Given this list of marker genes MRPL45, S100A11, KRBA1, PLPP1, PHB1, STMP1, DGKE, KDM2B, NEDD9, CLCF1, CDK1, PIP4K2A, FAM53A, TMEM35A, COPS7A, APOOL, FNBP4, PTPRCAP, NFKBIA, IDH3A, DUSP2 (dual specificity phosphatase 2), C1QBP, GBP6, SUGP1, XIST, NUFIP1, LHPP, ABCA3, ZNF654, PHIP (pleckstrin homology domain interacting protein), TMEM19, PPP4R3B, PTCD2, RPAP3, WDR26, STAT6, NCOA2, KANSL2, TDP2, LSM3, COX17, MRPS14, ETFA, IGSF9, MLLT3, AKR1A1, CELSR1, ERAL1, SLC9A8, GTF2H3, MTHFS, GPHN, TOPBP1 (DNA topoisomerase II binding protein 1), OCIAD1, IFNG, TNFSF8, BAG2, TM2D3, FBXO11, MAPK1, TMEM71, LACTB, POLK, NAA20, PARN, LYSMD2, MGST2, DUT, DNAJC28, TM9SF4, MRPL22, IFT27, STAG2, TUBGCP5, CEBPZOS, SHPRH, BPHL, LYPLAL1, CCDC47, PURG, MINDY3 (NCBI Gene Id 80013), RHOD, PPM1A, ALCAM, MDM2, CASP1, RGS3, NUDCD1, FOXO3, RNF135, FEN1, ARL4A, NFKB2, HERC4, POLR2G, IL2, SEPTIN2, PPCDC, SGMS1, RAMP3, RARG, NTRK3, FBXL20, BCAP29, DMD, GRIA3, DBT, TOP3B, TNFRSF14 (TNF receptor superfamily member 14), SRPK2, NUP85, GNPAT, DFFB, GTF2H1, SLFN13, NOTCH2, TCF7, DDX39B, MCCC1, IGF1R, SYNGR2, IMMT, DCAF12, CCN4, TMC6, CYBA, ILF3, MRPL16, SELENOS, TSTD1, IRAK1, NR3C1, NUP37, TRAF5, M6PR, PHLDB1, MAPK8, FAM81A, RGS2, TRPT1 (NCBI Gene Id 93089), SMARCA2, PPIC, SCFD1, SYNJ2, ATM, ANAPC1, WASHC3, LHX2, XRN1, CLPP, FANCF, ASTE1, MRPL21 (NCBI Gene Id 64993), HMGCS1, EXTL3, USP1, TPRA1, USP29 (ubiquitin specific peptidase 29), NUP188, FOXK1, FUNDC1, EZH2, SFT2D1, CCNE1, RPRD1A, STK3, WARS1, MAPRE2, SEC11C, SF3B3, CYTH3, PRPF8, TMEM243, PPP4R2, AKR1B10, CCDC90B, GMPR (guanosine monophosphate reductase), COMTD1, NUCKS1, NCAPG2 (non-SMC condensin II complex subunit G2), NABP2, PHYKPL, DENND2D, RNF123, SMC3, FGR, CDKN1A, NASP, C11orf58, PANK1, CUBN, RCCD1, SDHA, AARD, DDB2, SERPINB9, ACSL5, PPIF, here is a description of the gene set: studied in species Homo sapiens Genes up-regulated in IKZF1 knockout: lymphoid-primed multipotent progenitors versus granulo-monocyte progenitors. from publication Ng SY, Yoshida T, Zhang J, Georgopoulos K (PMID 19345118) Human Gene Set: GSE15330_LYMPHOID_MULTIPOTENT_VS_GRANULOCYTE_MONOCYTE_PROGENITOR_IKAROS_KO_UP Regulation of lineage potential and transcriptional priming by Ikaros. New insight is provided into a bivalent regulation of lineage priming in the HSC and its lympho-myeloid restricted progeny the LMPP by the lymphoid lineage-determining factor Ikaros Whereas Ikaros is responsible for the activation of a cascade of lymphoid expression programs and for the establishment of lymphoid potential from the HSC to the LMPP it is also responsible for the repression of stem cell and erythroid genetic programs that are incompatible with further lineage restrictions emanating from the LMPP